Given this list of marker genes AR, PARP1, FOXA1, PPP5C, HDAC6, TAF1, WBP2, SRARP, SKP2, PAK1, HDAC2, PAGR1, FSHR, HDAC1, LMO3, KMT2D, MED1 (mediator complex subunit 1), here is a description of the gene set: Human Gene Set: GOBP_POSITIVE_REGULATION_OF_INTRACELLULAR_STEROID_HORMONE_RECEPTOR_SIGNALING_PATHWAY species: Homo sapiens Any process that activates or increases the frequency, rate or extent of the activity of any intracellular steroid hormone receptor signaling pathway.